The following is a description of a gene set: Mouse Gene Set: GOBP_PROTEIN_MONOUBIQUITINATION species: Mus musculus Addition of a single ubiquitin group to a protein., and this is the list of marker genes: Stub1, Rbx1-ps, Huwe1, Dtl, Ube2d3, Birc2, Rbx1, Pex2, Trim25, Cdc34, Skp1, Ube4b, Rnf126, Cul1, Obi1, Ube2w, Ubb, Toporsl, Trim37, Fancm, Fancl, Wdr48, Ube3d, Itch, Neurl1a, Zc4h2, Pdcd6, Ube2r2, Marchf7, Mgrn1, Cbl, Msl2, Rnf220, Nedd4 (NCBI Gene Id 639396), Rnf10 (ring finger protein 10), Trim56, Ube2t, Prkn, Trim41, Cul3, Zfp598, Ube2n, Kbtbd8, Klhl22, Topors, Pex12, Tsg101, Fbxl2, Trim21, Ube2e2, Rnf152, Pef1, Rad18, Ube2o, Klhl12, Nedd4l, Trim63, Ube2e1